The following is a description of a gene set: species: Homo sapiens Human Gene Set: GOBP_DENTATE_GYRUS_DEVELOPMENT The process whose specific outcome is the progression of the dentate gyrus over time, from its formation to the mature structure. The dentate gyrus is one of two interlocking gyri of the hippocampus. It contains granule cells, which project to the pyramidal cells and interneurons of the CA3 region of the ammon gyrus., and this is the list of marker genes: CDK6, SMO, PIANP, NEUROD6, LMX1A, ATAT1, PROX1, BTG2 (BTG anti-proliferation factor 2), DRD1, LEF1, POMGNT1, NR2E1, LARGE1, PTEN, TMEM108 (transmembrane protein 108), FXR2, EMX2 (empty spiracles homeobox 2), FBXO41, FEZF2, BLOC1S6, POMT2, TUBA1A, NEUROD1, MDK, VPS13B, FXR1